Given this list of marker genes Utp11, Rexo5, Ngdn, Heatr1, Riok2, Rpl5, Polr1a, Pdcd11, Bud23, Rbfa, Tsr1, Tfb2m (NCBI Gene Id 269153), Znhit6, Pwp2 (NCBI Gene Id 76236), Polr1g, Myc, Nol7, Rps27, Trmt112, Kri1, Rrp36 (ribosomal RNA processing 36), Rps8, Slfn8, Gar1, Wdr12, Eif6, Top1, Utp6, Rps16, Ippk, Nob1, Lsm6, Chd7, Dis3l, Ang5, Tbl3, Nudt16, Rpl35a, Usp36, Emg1, Fcf1, Exosc5, Npm3, Ddx21, Rpl35, Sirt7, Rrp7a, Exosc1, Rrp9 (NCBI Gene Id 27966), Rrp1, Ang4, Wdr55, Nsa2, Polr2e, Exosc8, Pwp1, Rpf2, Nop10, Nop9, Riok3, Polr1d, Exosc10, Dkc1, Smarcb1, Ang2, Riok1, Znhit3, Cdkn2a, Dedd, Ddx27, Brix1, Nop53, Rps19, Mrm1, Nop14, Rpf1, Ncl, Mars1, Mettl18, Ang6, Rpl7 (ribosomal protein L7), Nsun5, Rps28, Rpusd1, Mtor, Slx9, Zcchc4, Ebna1bp2, Rpl7l1, Rpl14 (ribosomal protein L14), Rrp8, Nol11, Macroh2a2 (NCBI Gene Id 404634), Pop7, Pes1, Rps21, Ddx54, Exosc2, Frg1, Ybey, Pop4, Utp3, Nsun4, Tcof1 (NCBI Gene Id 21453), Rrp15, Pelo, Ercc3, Mphosph10, Nat10, Utp25, Prkdc, Lyar, Gtf3c1, Utp4, Dcaf13, Rps7, Tfb1m, Pop5, Mettl16, Rpp25, Rpp40, Rpusd2, Naf1, Rbm34, Rrp1b, Trmt2b, Fbl, Nvl, Myg1, Exosc9, Sart1, Utp14a, Dicer1, Ang, Polr1b, Dis3, Mrm3, Polr1f, Kat2b, Gtf2h5, Tsr3, Tsr2, Taf1b, Rpl26, Ercc2, Slfn14, Wdr74, Mphosph6, Fdxacb1, Bms1, Snu13, Exosc7, Ubtf, Fbll1, Mtrex, Esf1, Exosc6, Rpl27, Imp3, Rps17, Rpl11, Tent4b, Ddx52, Ddx47, Pak1ip1, Utp14b, C1d, Wdr75, Nol8, Pih1d2, Rexo1, Macroh2a1, Exosc4, Rps25, Rnasel, Ddx17, Nol9, Ddx18, Trir, Wdr36, Nsun3, Eri1, Mrto4, Rpp38, Rps15, Pa2g4, Rps27rt (ribosomal protein S27, retrogene), Rcl1, Sbds, Srfbp1, Rps14, Ercc6, Nol10, Wbp11, Las1l, Rpp30, Rps6, Pelp1 (proline, glutamic acid and leucine rich protein 1), Imp4, Dimt1, Spin1, Mettl5, Dhx37, Gtpbp4, Mettl15, Urb1, Exosc3, Rexo4, Wdr46, Ern2, Drosha, Smarca4, Mrm2, Krr1, Utp15, Polr1e, Trp53, Sde2, Wdr43, Bop1, Ftsj3, Npm1, Slfn9, Mterf4, Nhp2, Ddx51, Rps24, Ddx49, Ppan, Eif4a3, Xrn1, Ddx56, Suv39h1, Nol6 (NCBI Gene Id 99993), Rpl7a, Bysl, Rrs1, Utp18, Utp20, Rpusd4, Utp23, Pih1d1, Ddx10, Pin4 (NCBI Gene Id 69713), Mak16, Wdr18, Ddx11, Cavin1, Isg20, Ak6, Nop2, Rps6-ps4, Abt1, Ythdf2, Wdr3 (WD repeat domain 3), here is a description of the gene set: Mouse Gene Set: GOBP_RRNA_METABOLIC_PROCESS The chemical reactions and pathways involving rRNA, ribosomal RNA, a structural constituent of ribosomes. studied in species Mus musculus